The following is a description of a gene set: Human Gene Set: GOBP_PROTEIN_LOCALIZATION_TO_CELL_CORTEX A process in which a protein is transported to, or maintained in, the cell cortex. species: Homo sapiens, and this is the list of marker genes: GPSM2, NUMA1 (NCBI Gene Id 4926), NUBP1, PPP1R9B, PLK1, EPB41L2, SAPCD2, ILK (integrin linked kinase), MISP, EPB41, EZR, GNAI1